Given this list of marker genes Pik3c3, Gba1, Atg13, Atg101 (NCBI Gene Id 68118), Rb1cc1, Rab3gap2, Rabl3, Hhatl, Svip, Dbi, Ulk1, Rab3gap1, here is a description of the gene set: studied in species Mus musculus Mouse Gene Set: GOBP_REGULATION_OF_PROTEIN_LIPIDATION Any process that modulates the frequency, rate or extent of protein lipidation.